Given this list of marker genes Ramp1, Gpr182, Crcp, Calcr, Ramp2, Ramp3, Calcrl, here is a description of the gene set: Combining with any member of the calcitonin family (e.g. adrenomedullin, adrenomedullin 2 (intermedin), amylin, calcitonin and calcitonin gene-related peptides (CGRPs)) to initiate a change in cell activity. studied in species Mus musculus Mouse Gene Set: GOMF_CALCITONIN_FAMILY_RECEPTOR_ACTIVITY